The following is a description of a gene set: The chemical reactions and pathways resulting in the formation of ADP, adenosine 5'-diphosphate. studied in species Homo sapiens Human Gene Set: GOBP_ADP_BIOSYNTHETIC_PROCESS, and this is the list of marker genes: AK2, AK5, AK1, AK3, AK4